Given this list of marker genes Sim2, Rdh9, Ufd1 (ubiquitin recognition factor in ER-associated degradation 1), Arhgap24, Rrm2, Sox4, Phgdh, Cd302, Ggt5, Sprr1a, Tgfa, Mapk10, Polr1e, Socs2, Klrc1, Pkm, Chd4, Bhlhe40, Mertk, Ddx49, Tex21, Myadm, Grwd1, Ebna1bp2, Mcm7, Itgb1, Aarsd1, Smpd2, Ifng, Fstl1, Cyp24a1, Ppargc1a, Cpd, Bcl11b, Plbd2 (NCBI Gene Id 71772), Eif5a, Gabra1, Pdk3, Bicd1, Ift46, Cxcr6, Mthfd1, Nop2, Hopx, Camk4, Cacna2d3, Cxcl10, Adam34, Pkp2, Eps8, Acsf3, Il13, Nat8f4, Abce1, Slc15a1, Bub1b, Gpi1, Klkb1, Pinx1, Tk1, Wwtr1, Klra7, Kctd12, Socs3, Ddx3y, Myo5a, Card10, Ptpn22, Sgms1, Oaf, Mrpl12, Ly86, Ctla2a, Hnrnpab, Cct7, Zfp612, Sh3bgrl2 (SH3 domain binding glutamic acid-rich protein like 2), Tacc2, Klf4, Rps6ka2, Slc6a3, Sars1, Syt6, Ccdc117, Vegfd, Chst14, Ppp3cc, Phf21a, Enc1, Zbtb16, Ccr7, Limd2, Dph5, Ntrk3, Timeless, Prmt1, Marcksl1, Snhg16, Enpp2, Mmp13, Atp6ap2, Hip1, Tlr3, Fzd6, Ebf1, Rbm6, Lats2, Zfp207, Klra3, Teddm3, Fmn2, B3gnt5, 0610010K14Rik, Coro1a, Gas1, Ms4a4b, Mcm2 (NCBI Gene Id 17216), Chchd6, Slc16a2, Spon1, Wwc2, Daglb, Tfrc, Ruvbl1, Itsn1, Tmem30a, Ctsd, Ppil2, Klrb1b, Xcl1, Zc3h12c, Clnk, Flna, B4galnt1, Rian (NCBI Gene Id 75745), Ctla2b, Csn1s2a, Misp, Psmd13, Ap3s2, Galk1, Cacnb4, Speg, Mcm3, Nkg7, Sh3d19, Tcf7, Obox1, Dst, Nedd9, Pfkl, Sox6, Cadm1, Klra8, Kcnn4, Tmc1, Cd247 (CD247 antigen), Pfdn6, Litaf, Hsd11b1, Il1b, Map2k7, Ptprj, Serpinb1a, Ttc39b, Trp63 (NCBI Gene Id 22061), Jchain, Reck, Cd7, Mdfic, Rnf25, Tm6sf1, Sv2a (synaptic vesicle glycoprotein 2a), Ncapd2, Polg, Tnnt1, Nucb2, Gjd2os, Oprm1, Gem, Igf1, Arl6, Rnf19b, Id4, Ssrp1, Slc25a53, Abcb9, Dtl, Fen1, Smo (NCBI Gene Id 319757), Cdca5, Atad3a, Suv39h2, Ifitm2, Evi5, Polr1d, Prrx1, Ptprf, Akr1c18, Ly6c1, St13, Cfhr2, Mpp4, Gfm1, Man1a, Car8, Dennd5a, Hoxa13, Lmnb2, Dnah8 (dynein, axonemal, heavy chain 8), Dsp, Upf1, Crim1, Bnc1, Twf1 (NCBI Gene Id 19230), Or5b106, Lilrb4b, Col19a1, Klrk1, Ighg2b, Fgl2, Asns, Mmaa, Rcbtb2, H1f4, Mcm5 (minichromosome maintenance complex component 5), Cxcr3, Rrp12, Serpina3g, Oasl2, Gpat4, Cxcl2, Zc3h7a, Prss23, Hspa1b, Tle1, Epha7, Myo1f, Klra5, Slc5a4a, Cdh1, Acly, Ica1, Fnbp4, Plscr1, Ppp2r5c, Mrpl38, Rell1, Fasl, Ncapg, Igha, Dock7, Ripor2, Hey1, Enpp3, Ahnak, Csn3, Zfp91, Fbxl3, Fkbp9, Epb41l3, Syt7, Apcdd1, Tex9, Kcnj8, Plaur, Cyb5b, Eng, Klrd1, Mrpl19, Fhl1, Napsa, Ccl5, Fblim1, Atmin, Tars1, Cd44, Elovl4, Rgs1, Ribc2, Syncrip, Id3, Ppp4c, Pvr, Nisch, Klrb1c, Gnb2, Tyms, Lyst, Tirap, Tasp1, Nhp2, Gzmb, Slc41a2, Chst7 (carbohydrate sulfotransferase 7), Tesc (tescalcin), Vcp-rs, Wdfy1, Tkt, Slc25a13, Wdr54, Homer2, Ptgs2, Ctnnbl1, Proz, Col11a1, Shmt2, Tab1, H19, Aspn, AY074887, Cbarp, Ifitm10, AW112010, Lyz2, Aip, F2r, Gm14325, Sorl1, Cisd1, Tubb2b, Galnt3, Cd38, Wipf1, 1500002F19Rik, Atp5mc1, Postn, Il2rb, Nr1d2, Tacc3, Ncl, Pdcd1, Prim2, Tmem242, Habp2, Tsc22d3, Vmn1r13, Otud5, Ube3a, H2-Q4, Hexa, Dhrs3, F2rl1, Gramd2b, Jun (jun proto-oncogene), Cd244a, Clca3a1, Exosc10, Pla2g2d, Rhot2, Lztfl1, Akap9, Tnpo2, Pak1, Ska1, Ranbp1, Trgv4, Prxl2b, Mrpl54, Pfn2 (profilin 2), Sfrp2, Slc35f5, Tcf4, Ripk3, Efemp1 (NCBI Gene Id 216616), Ebf2, Irgm2, Dsg2, Syce2 (NCBI Gene Id 71846), Ahr, Pdlim4, Ifitm1, Ccr5, Brd3, Art2b, Edf1, Siae, Actb, Cd160, Ly75, Sgo1, Sdad1, Tspan31, Gca, Gm29761, Ccl4, Cxadr, Rps14, Klf6, Rflnb, Edil3, Pde7a, Stat5b, Ppih, Stxbp4, Sat1, Map4k5, Tcf7l1, Rhoc, Cpeb1, Ndufb10, Psmc4, Hrh1, Gpatch4, Galnt4, Myo1e, Sox13, Slc22a29, Mcoln2, Tulp3, Kif22, Rps18, Endod1, Ccr9, Anxa1, Hsp90aa1, Prmt3, Als2, Ccr1 (NCBI Gene Id 12768), Mtch1, Ipo4, Slc13a3, Plin2, Fkbp1a, Cd36, Mpeg1, Armc6, Psg16, Frmd4b, Tent5c, Stab2, Tnpo3, Csrp1, Kif11 (kinesin family member 11), Magi1, Cubn, Igkc, Scamp1, Zfp189 (zinc finger protein 189), Mef2c, Tjp1, Grap2, Epha3, Dtymk (NCBI Gene Id 98609), Stat4, Dapk2, Atp13a2, Igfbp4, Sp4, Chaf1b, Gsta4, Stmn1, Ptprd, Vmn1r62, Trf, Ldhb, Scd2, Zfp352, Rad54l, Abcb1a, Slc28a2, Aldoa, Gpr34, Gtf2a1, Ms4a6d, Calml4, Sesn1, Sec61a2, Runx2, Spon2, Dhrs4, Scube2, Slamf7, Sgcb, Kif1b, Cdc23, Lrrk1, Lgi1, Yes1, St3gal6, Nrgn, Ppp3r1, Fkbp4, Smpd4, Xiap, Sgk1, Prxl2a, Fos, Ifngr1, Slc6a15, Ciita, Mycn, Tbx21, Zbtb21, Stam2, Slc40a1, Cox5b, Bud31, Sytl2, Tpi1, Matk, Pgap4 (NCBI Gene Id 77263), Prf1, Cdk4, Gm568, Plagl1 (NCBI Gene Id 70469), Vdr, Pmepa1, Fhip1b, here is a description of the gene set: from publication Matsuda JL, Zhang Q, Ndonye R, Richardson SK, Howell AR, Gapin L (PMID 16357323) Mouse Gene Set: MATSUDA_NATURAL_KILLER_DIFFERENTIATION studied in species Mus musculus Genes changed between developmental stages of Valpha14i natural killer T lymphocyte cells (NKT). Valpha14i natural killer T (NKT)-cell function has been implicated in a number of disease conditions. The molecular events that drive Valpha14i NKT-cell development remain elusive. We recently showed that T-bet is required for the terminal maturation of these cells. Here we identify some of the genetic targets of T-bet during Valpha14i NKT-cell lineage development. Microarray gene-expression analyses on developing Valpha14i NKT cells were performed and provide a molecular framework to study these maturation events. In vitro ectopic expression of T-bet in immature Valpha14i NKT cells, which do not yet express T-bet, was sufficient to promote Valpha14i NKT-cell maturation, driving the expression of multiple genes, including those that participate in migration, survival, and effector functions. By regulating the expression of T-helper 1 (Th1)-associated cytokines, chemokines, chemokine receptors, and molecules involved in cytolysis, T-bet defines the unique lineage attributes of mature Valpha14i NKT cells and acts to link these attributes to a developmental process.